The following is a description of a gene set: species: Homo sapiens The process in which a purine nucleoside is transported across a membrane. A purine nucleoside is a purine base covalently bonded to a ribose or deoxyribose sugar. Human Gene Set: GOBP_PURINE_NUCLEOSIDE_TRANSMEMBRANE_TRANSPORT, and this is the list of marker genes: SLC29A1, SLC25A26, SLC29A2, SLC28A2, SLC28A3